Given this list of marker genes MRPL49, ZNF426, CAPZA2, TMEM14C, HIC2, ZFYVE19, MRPL19, HNRNPUL1 (heterogeneous nuclear ribonucleoprotein U like 1), ADAT2, RPS6, SURF6, CLCN7 (chloride voltage-gated channel 7), ZNF841, H1-10, TMEM63A, GABARAP, VAPA, WEE1, ZNF276, GOLGA7, ADIPOR2, SLC30A5, FOXO4, ZNF124, OGFOD2, OSBP, FUBP1, TUBA1A, TMEM183A, NPRL2, IREB2, CERS2, DFFB, EIF5B, RASSF5, DGKZ, SRSF9, CCDC134, ZFP82, EVC, PPP1R21, MTA1 (metastasis associated 1), MGME1, ABCB7 (NCBI Gene Id 8252), NANS, NRAS, SFTPA1 (NCBI Gene Id 653509), NR2F6, NELFA, NEK1, SLC25A46, COPG2, RAC1, EIF4A1, TRIM11, SDR42E1, ADRA2A, NCOR1, GADD45G, RDH13, ZBTB7A, CIDEC, SIDT2, ENTPD5, MRPS26, EPCAM, ROM1, TAF11, ZDHHC4, PNLIPRP1, MFAP1, NCLN, FAM76B, HOXB3, STIP1, ACLY, SLC39A11, TM9SF3, CGGBP1, BTBD1, PHPT1, STK19, GNPAT, TRPC5 (NCBI Gene Id 7224), PHAX, KIAA0930, GNB1, FUT1, HLA-DMA, POLR1D, GCDH, EGLN2, MOSPD2, BUB1, ARPC4, DESI2, KXD1, RAB3GAP2, LSM3, TLN1 (NCBI Gene Id 7094), STOML2, TM6SF1, ERCC3, CLYBL, RASAL3, ZFP90, RNFT1, CPPED1, ZBTB33, PRKAB1 (NCBI Gene Id 5564), CSTF2, TIMM50, NUFIP1 (nuclear FMR1 interacting protein 1), CYB5R1, NSUN5, GYS1, SLC25A26, AP1G1, TNPO3, HPRT1, PROKR1, N4BP3, TMED10 (NCBI Gene Id 10972), STARD3NL, BATF, CLINT1, MCM2, TAF10, IVNS1ABP, SVIL, PHKG2, IKZF2, TNFRSF13B, POLR2M, TMEM116, MRPL34, ZDHHC5, SDHAF1, SLC44A4, CREB3L1 (NCBI Gene Id 90993), TMEM203, HPS3, FKBP4, REPIN1, FBXO9, PES1, JTB, PRKCZ, AGK, SNX4, LIMK1, SKP1, CYBC1, ZMIZ2, ZCCHC8 (zinc finger CCHC-type containing 8), NFAM1, MDP1, ELP2, SLC50A1, USP26, SWSAP1, MTO1, WDR12, IGF2R, EXOSC4, TANGO2, C19orf53, RGS19, ADAM15, STK35, DIO1, RAB23, R3HCC1, PEX2, PARP3, KCNAB2, CD300LF, RNH1, GREM2, CDC20, KMO, NMNAT3, TTC1, ADCY7, DDX19B, PIP4K2C, PDZK1, PRPSAP2, RHOD, CEP19, CENPQ, NCKIPSD, ZNF688, C15orf39, EMC10, SCAND1, SLC25A45, SEPTIN8, CDKN2C, SUMO3, here is a description of the gene set: mouse primary BMDCs were stimulated with tlr ligands and gene expression changes were profiled on Affymetrix arrays Human Gene Set: GSE17721_CTRL_VS_CPG_1H_BMDC_UP studied in species Homo sapiens Genes up-regulated in comparison of control dendritic cells (DC) at 1 h versus those stimulated with CpG DNA (TLR9 agonist) at 1 h. from publication Amit I, Garber M, Chevrier N, Leite AP, Donner Y, Eisenhaure T, Guttman M, Grenier JK, Li W, Zuk O, Schubert LA, Birditt B, Shay T, Goren A, Zhang X, Smith Z, Deering R, McDonald RC, Cabili M, Bernstein BE, Rinn JL, Meissner A, Root DE, Hacohen N, Regev A (PMID 19729616)